Given this list of marker genes Trim5, Ptx3, Eif2ak4, Lrrc19, Tmeff1, Ythdc2, Tmem41b, Paip1, Rab5a, Ccl3, Smc5, Ccl8, Cdk9, Mre11a, Trim10, Ciita, Ly6e, Epg5, Cav2, Nlrp6, Trim30b, Phb1, Trim56, Nbn, Zdhhc20, Ep300, Tfap4, Rrp1b, Jun, Apoe, Zc3h12a, Ctdp1, Trim12a, Apcs, St6galnac1, Cdc42, Hspa8, Zdhhc8, Ifitm1, Rab29, Ifitm7, Ifitm6, Trim12c, Trim8, Gsn, Ifitm3, Vapa, Cfl1, Ccl5, Cd74, Zdhhc9 (zinc finger, DHHC domain containing 9), Pcx, Tardbp, Trim30a, Hmga2, Nod2, Smarca4, Trim31, Card9 (NCBI Gene Id 332579), Pou2f3, Ifng, Csf1r, Trim30c, Snx3, Ccnt1, Smc6, Muc2, Ltf, Rest, Pik3c2g, Nucks1 (NCBI Gene Id 98415), Pik3c3, Pi4ka, Zfyve1, Snw1, Zfp639, Prkn, Sprr2a1, Trim11, Trim26, Cx3cr1, Smarcb1, Mid2, Hpn, Vapb, Inpp5k, Ppib, Ifitm2, Fbxl2, Fcnb, Trim59, Fmr1, Rock2, Taf11 (TATA-box binding protein associated factor 11), Trim25, Sp1, Rad50, Lef1, Brd4, Ccnk, Stom, Napepld, Chd1, Igf2r, Lrrc15, Tbc1d20, Eef1a1, Hdac1, Eea1, Ddx56, Trim30d, Fasn, here is a description of the gene set: Mouse Gene Set: GOBP_HOST_MEDIATED_PERTURBATION_OF_SYMBIONT_PROCESS The process in which an host alters or subverts a process in a symbiont organism. The symbiont is defined as the smaller of the organisms involved in a symbiotic interaction. species: Mus musculus